Given this list of marker genes HRH1, APLN, OXTR, HTR2A (NCBI Gene Id 3356), EDN1, MAP2K1, KCNMB2, FGA, ADM, ADRA1D, F2R, ADD3 (adducin 3), ADRA1A, AGTR1 (angiotensin II receptor type 1), ECE1, KCNMB4, SMTNL1, ZDHHC21, ADRA2A, ADRA1B, FGG, FGB, ACE, AVP, ACE2, AGT, FAAH, CAV1, ATP1A2, RHOA, ITGA9, ARHGAP42, MTNR1B, LEP, CD38, PER2, KCNA5, EDN2, STUB1, TACR1, SVEP1, DOCK4, AVPR2, TRPM4, BMPR2, HTR1A, GJA5, BDKRB2, P2RX1, EDN3, MMP2, ITGA4, ATP2B1, DBH, HRH2, AVPR1A, TBXA2R, ITGB1, AVPR1B, ADRA2B, ASIC2, CASR, MIR21, ADRA2C, DOCK5, TBXAS1, ABL1, here is a description of the gene set: Any process that modulates the frequency, rate or extent of reductions in the diameter of blood vessels. species: Homo sapiens Human Gene Set: GOBP_REGULATION_OF_VASOCONSTRICTION